Given this list of marker genes YPEL5 (NCBI Gene Id 51646), ARFGAP2, AMMECR1L (NCBI Gene Id 83607), RHOBTB1, PLEKHA5, ENAH, TET1, PLCB4, ADGRL1, ING3, FOXP1, KCNK10, MAP3K4, PDCD4, RALGDS, EML4, PPM1E, POLR2D, ZNF592, PPP2R2A, ITGB1, FOXO1, GREM2, SACS, LMO3, XKR6, PLEKHA3, BAGE2, TRAM1, TPM3, DUSP10, PFN2, PDE4D, KLHL3, PRUNE2 (prune homolog 2 with BCH domain), TUB, FCHO2, CSNK1G1, ABCA1, CFL2, LAPTM4A, TCF12, GNG5, CELF6 (NCBI Gene Id 60677), IDH2 (isocitrate dehydrogenase (NADP(+)) 2), SLITRK3, TMPO, HBEGF, DAP, CELSR3, RPS6KA3, KCNK2, RIMBP2, TLE4, USP47, PTPN4, SPOPL, BRMS1L, CELF2 (NCBI Gene Id 10659), PLAG1, PDCD6, SERP1, PEX19, MEF2C, RAB11FIP4 (RAB11 family interacting protein 4), MTMR6, RCN2, CILK1, BNIP3L, GATAD2B, DCX, PRKCA, SIN3A, SRSF11, DGCR2, SNCB, AP3M1, DAGLA, CTNNA2, SPRY3, PPP2R5C, QKI, PPP2CB, OSBPL8, NADK2, CSNK1G3, GSE1, ERP44, PPP2CA (NCBI Gene Id 5515), SMCO4, STK38L, KCNJ14, PPP1R14B, IRS1, SLITRK1, PKP4, SSRP1, SLC35A1, BZW1, EPHA4, THEM4, PLAGL2, SNX1, ACVR2A, ZFYVE26, ARHGAP21, RNF138, CHRD, NCS1, PSEN2, CDK5R1, RALA, BTG1, RAB8B, ZDHHC6, HECTD2, TMSB4Y, VPS37A, ABRAXAS2, CTDSP1, FRMD6, PHLDB2, TTC7B, VDAC1, CTDSPL, TMED7, ARPP19 (cAMP regulated phosphoprotein 19), UNC13B, HAPSTR1, AGO2, ANKRD13C, SLC44A1, SCYL3 (NCBI Gene Id 57147), YES1, FOXN2, JADE2, TMSB4X, LRP6, CLCN3, PIM1, TMSB4XP8, ZMYM2, EGR1, GARRE1, MXD4, YOD1, SMPD3 (sphingomyelin phosphodiesterase 3), SEMA6D, MAPK8IP1, EZR, L3MBTL3, RAI14, AMD1, MBNL1, BAZ1B, FAM76B, MAL2, OGT, PAM, PHF6, SRSF2, SLC22A23, TPM1, ARHGEF18, DTNA, PTDSS1, NR3C1, BACH2, NCK2, ZFPM2, SLAIN1, SOX6, here is a description of the gene set: species: Homo sapiens Genes having at least one occurence of the motif GTGCCAT in their 3' untranslated region. The motif represents putative target (that is, seed match) of human mature miRNA hsa-miR-183 (v7.1 miRBase). Human Gene Set: GTGCCAT_MIR183